Given this list of marker genes CCN1, FGF4, RARA, GDF5, FGF2, here is a description of the gene set: Human Gene Set: GOBP_CHONDROBLAST_DIFFERENTIATION studied in species Homo sapiens The process in which a mesenchymal cell, acquires specialized structural and/or functional features of a chondroblast. Differentiation includes the processes involved in commitment of a cell to a chondroblast fate. A chondroblast is a precursor cell to chondrocytes.